Given this list of marker genes Ndc1, Snx24, Tmem59, Chd6, Abca8b, Mcm6, Xkr5, Tmem68, Nrbp2, here is a description of the gene set: Genes predicted to be targets of miRBase v22 microRNA mmu_miR_9b_5p in miRDB v6.0 with MirTarget v4 prediction scores > 80 (high confidence targets). from publication Chen Y, Wang X (PMID 31504780) Mouse Gene Set: MIR_9B_5P studied in species Mus musculus